The following is a description of a gene set: studied in species Homo sapiens Human Gene Set: GOBP_NEGATIVE_REGULATION_OF_RELEASE_OF_SEQUESTERED_CALCIUM_ION_INTO_CYTOSOL Any process that stops, prevents, or reduces the frequency, rate or extent of the release into the cytosolic compartment of calcium ions sequestered in the endoplasmic reticulum or mitochondria., and this is the list of marker genes: GSTO1, FKBP1B, NTSR1, CALM1, CALM2, TGFB1